The following is a description of a gene set: Any process that stops, prevents, or reduces the frequency, rate or extent of the Notch signaling pathway. studied in species Homo sapiens Human Gene Set: GOBP_NEGATIVE_REGULATION_OF_NOTCH_SIGNALING_PATHWAY, and this is the list of marker genes: HIF1AN (hypoxia inducible factor 1 subunit alpha inhibitor), MIR141, MIR1224, LFNG, AKT1, DLK1, CCNC, ARRB1, NEURL1, TCIM, DLX2, HEY2, ZBTB7A, TSPAN15, BMP7, BEND6, HEY1, RITA1, MAGEA1, CDK3, ARRDC1, MMP14, EGFL7, FBXW7, DLL4, BCL6, MIR200C, LRRK2, METTL3, CBFA2T2, DLX1, SLC35C1, CHAC1, HERC2, WWP2, DLL3, NFKBIA, OVOL2, YTHDF2 (YTH N6-methyladenosine RNA binding protein F2), DLL1, DLK2, NRARP, GATA2 (NCBI Gene Id 84724)